The following is a description of a gene set: Human Gene Set: GOBP_CELL_SURFACE_TOLL_LIKE_RECEPTOR_SIGNALING_PATHWAY studied in species Homo sapiens The series of molecular signals initiated by a ligand binding to a cell surface pattern recognition receptor (PRR) of the toll-like family., and this is the list of marker genes: ECSIT, NR1H3, CYBA, NMI, APPL1, MIR140, IRAK4, TRIL, TLR5, TRIM32, PJA2, DAB2IP, PIK3R1, IFI35, MIR149, PIK3AP1, TRAF3, MIR146A, MIR708, ACOD1, TLR4, FLOT1, CD14, MIR200C, TLR2, MIR200B, PELI1, LTF, TBK1, LBP, MYD88, OAS1, LILRA2, MIR20A, BPIFB1, NAGLU, TLR1, IRAK1, TAX1BP1, MIR210, MFHAS1, TNFAIP3, RELA, SQSTM1, LETMD1, PRKCE, TICAM2, S100A14, LYN, TNIP3, TREM2, NR1D1 (NCBI Gene Id 9572), ZNRF1, TICAM1, RIPK2, TRAF6, NFKBIA, TLR6, MAP3K7, IRAK2, IRF3 (NCBI Gene Id 3661), NINJ1, CHUK (component of inhibitor of nuclear factor kappa B kinase complex), WDFY1, TIRAP, RAB11FIP2, F2RL1, LGALS9, TMEM126A, SCIMP, HMGB1, TNIP2, PTPN22, LY96 (NCBI Gene Id 23643), RAB7B, APPL2